The following is a description of a gene set: Enables the transfer of fatty acids from one side of a membrane to the other. Fatty acids are aliphatic monocarboxylic acids liberated from naturally occurring fats and oils by hydrolysis. Human Gene Set: GOMF_FATTY_ACID_TRANSMEMBRANE_TRANSPORTER_ACTIVITY studied in species Homo sapiens, and this is the list of marker genes: SLC27A6, SLC2A1, SLC43A3, ABCD1, FABP4, SLC27A1, SLC27A5, SLC5A8, SLC27A4, FABP3, SLC22A9 (NCBI Gene Id 221106), ABCD4, CD36, FABP2, SLC27A2, MFSD2A, ABCD2, FABP5, ABCD3